Given this list of marker genes PLSCR1, RGS5, NNAT, TEX15, PERP, TNFRSF11B, CHODL, TINAGL1, THSD4, FOXA1, RGS4, SHROOM3, PAX1, MPPED2, GNA14, KCNMB4, CACNA1G, PARM1, WNT5B, COL2A1, PPP1R3C, NRN1, SNCA, SEMA4F, KCNA5, ACOT1, H4C1, CLCA3P, CLU, here is a description of the gene set: species: Mus musculus Transforming growth factor beta (TGF-beta) and platelet-derived growth factor A (PDGFAlpha) play a central role in tissue morphogenesis and repair, but their interplay remain poorly understood. The nuclear factor I C (NFI-C) transcription factor has been implicated in TGF-beta signaling, extracellular matrix deposition, and skin appendage pathologies, but a potential role in skin morphogenesis or healing had not been assessed. To evaluate this possibility, we performed a global gene expression analysis in NFI-C(-/-) and wild-type embryonic primary murine fibroblasts. This indicated that NFI-C acts mostly to repress gene expression in response to TGF-beta1. Misregulated genes were prominently overrepresented by regulators of connective tissue inflammation and repair. In vivo skin healing revealed a faster inflammatory stage and wound closure in NFI-C(-/-) mice. Expression of PDGFA and PDGF-receptor alpha were increased in wounds of NFI-C(-/-) mice, explaining the early recruitment of macrophages and fibroblasts. Differentiation of fibroblasts to contractile myofibroblasts was also elevated, providing a rationale for faster wound closure. Taken together with the role of TGF-beta in myofibroblast differentiation, our results imply a central role of NFI-C in the interplay of the two signaling pathways and in regulation of the progression of tissue regeneration. Human Gene Set: PLASARI_NFIC_TARGETS_BASAL_UP from publication Plasari G, Calabrese A, Dusserre Y, Gronostajski RM, McNair A, Michalik L, Mermod N (PMID 19752192) Genes up-regulated in MEF cells (embryonic fibroblast) upon knockout of NFIC.